Given this list of marker genes GRIN2A, GRIN3A, C14orf28, GRIK1, HTR3B, GRID2, HTR3C, GRIA3, GRIA1, GRIN2C, HTR3E, FFAR2, SHANK1, CHRM3, GRIN1, DLG4, FFAR1, NRXN1, GRIK3, GRID1, F2RL2, ADRB2, PLCB1, MEF2C, GRIN2B, GRIA2 (NCBI Gene Id 2891), CPEB4, ITPR1, GRIN2D, GNA11, GRIN3B, PTK2B, GRIK4, HTR3A, APP, NLGN1, GRIK2, GRIK5, F2, CAPN1, HTR3D, CLN3, CHRNA7, CDK5R1, GRIA4, ORAI1, here is a description of the gene set: The series of molecular signals initiated by activation of a ligand-gated ion channel on the surface of a cell. The pathway begins with binding of an extracellular ligand to a ligand-gated ion channel and ends with a molecular function that directly regulates a downstream cellular process, e.g. transcription. Human Gene Set: GOBP_LIGAND_GATED_ION_CHANNEL_SIGNALING_PATHWAY studied in species Homo sapiens